Given this list of marker genes POU3F3, SATB2, NSG2, ASTN2, GABBR2, ACAT2, LINC01102, CTNNA2, JAKMIP1, CRABP1, RNF182, GPRIN1, CNTN2, TTYH1, MIR124-1HG, CNGB1, KRTAP5-AS1, CALN1, CACNA1E, MAPT, VSTM2B-DT, SATB2-AS1, SNTG1, TUBB3, FST, RBFOX1, CHRNA3, TTC9B (NCBI Gene Id 148014), SOX2-OT, OLFM1, SNAP91 (synaptosome associated protein 91), FGF1, NOS1, CLVS2, LINC01965, GPM6B, B4GALNT1, LINC01322, SLC44A5, ENSG00000271860, HECW1, CHST8, TMOD1, STMN4, NWD2, APC2, EPHA3, DLGAP1, FRRS1L, NKAIN3, MAP1B, PTPRO, GRM5, SYT3, CNTNAP5, CNTNAP4, SYNGR3, PTPRR, L1CAM, KCNF1 (potassium voltage-gated channel modifier subfamily F member 1), CACNG2, NEUROD6, PATJ-DT, PPFIA2, RIMS4, KBTBD11-OT1, GLRA2, SULT4A1 (NCBI Gene Id 25830), ELOVL2, CHRM2, MLLT11, CELF5, ST8SIA5, RIMS3, PRIMA1, ZNF382, CEND1, CADM4, GAP43, SEPTIN3, NGFR, MIR137HG (NCBI Gene Id 400765), KCNK9, FAIM2 (Fas apoptotic inhibitory molecule 2), TRIM67, FRMPD4, PHOX2A, ATP1A3, PLD5, DLX1, POU3F2, CDK5R1, PCDHB15, KLHDC8A, NCAN, KCNQ3, GAL, ENHO, SYN2, CUX2, FUT9, ADRA1A, MYT1L, SEZ6, PCOTH, RORB, SLC18A3 (NCBI Gene Id 6572), LINC01122, KIF5A, FGF13, KCNB1, DAB1, ARPP21, VAT1L, PRPH (peripherin), NEUROD2, SCUBE1, NEFM, BHLHE22, HECW1-IT1, FOXG1, GPC6-AS1, MLIP (muscular LMNA interacting protein), CSMD2, CELSR1P1, TUBB2B, TMEM130, HAND2-AS1 (NCBI Gene Id 79804), MDGA2, SLC7A14, DPYSL5, TUBB4A, AMER2, PHACTR3 (NCBI Gene Id 85418), SLC6A15, ACHE, KCNH1, NKAIN1, BCAN, PAX6 (paired box 6), DCX (doublecortin), PIRT (NCBI Gene Id 649488), GPR85, PSD2, LHX2, MIR9-2HG, LINC01776, PHOX2B-AS1, TRIM9, B3GAT1, LINC00609, EPHA5, NELL1, PPP2R2B, HS3ST5, NXPH1, ALK, PDZD4, SLC5A7, GABRA3, UNC5D, TMEM132B, FAM163A, HS6ST3, MAPT-AS1 (MAPT antisense RNA 1), MIR9-3HG, ELAVL3, ST8SIA2, PCDHGB2, KIAA1549L, SCRG1, B3GALT1-AS1, DPF1, STMN2, ACTL6B, CHL1, PCDH19, JPH4, FAM200C, EEF1A2, TLCD3B, PHOX2B, CDH6, VIP, GDAP1L1 (NCBI Gene Id 93987), ATCAY, GRIA3, ADD2, SCRT2, MEGF10, DLX6-AS1, CNTN5, CSMD1, RAB15, ATP2B2, GRM3, ADCYAP1R1, PANTR1, LINC01551, TUBB2A, EML5, MGAT5B, DSCAM, LRRC7, CACNG7, ASTN1, CNR1, KLHL1, NEUROG2-AS1, DRAXIN, SHISA9 (shisa family member 9), FAM131B, here is a description of the gene set: from publication Cao J, O'Day DR, Pliner HA, Kingsley PD, Deng M, Daza RM, Zager MA, Aldinger KA, Blecher-Gonen R, Zhang F, Spielmann M, Palis J, Doherty D, Steemers FJ, Glass IA, Trapnell C, Shendure J (PMID 33184181) Marker genes curated from the annotated cluster as represented in the Descartes Human Gene Expression During Development database. Human Gene Set: DESCARTES_FETAL_LUNG_VISCERAL_NEURONS studied in species Homo sapiens The gene expression program underlying the specification of human cell types is of fundamental interest. The study authors generated human cell atlases of gene expression and chromatin accessibility in fetal tissues. For gene expression, the study authors applied three-level combinatorial indexing to >110 samples representing 15 organs, ultimately profiling ~4 million single cells. The study authors leveraged the literature and other atlases to identify and annotate hundreds of cell types and subtypes, both within and across tissues. Our analyses focused on organ-specific specializations of broadly distributed cell types (such as blood, endothelial, and epithelial), sites of fetal erythropoiesis (which notably included the adrenal gland), and integration with mouse developmental atlases (such as conserved specification of blood cells). These data represent a rich resource for the exploration of in vivo human gene expression in diverse tissues and cell types.